Given this list of marker genes MT-ND4L, MT-ATP8, MT-CO3, MT-ND3, MT-TS2, MT-ND1, MT-TR, ELAC2, TRNT1, MT-ND6, MT-TW, MT-ND2, MT-CO2, MT-TN, MT-TL1, MT-TL2, MT-TK, MT-TC, MT-TQ, MT-TG, MT-CYB, MT-ND4, MT-ND5, TRMT10C, MT-TI, PRORP, MT-TF, MT-ATP6, MT-CO1, MT-TT, MT-TP, MT-TA, MT-TD, MT-TS1, MT-TV (mitochondrially encoded tRNA-Val (GUN)), MT-TH, HSD17B10, MT-RNR1, MT-TY, MT-TM, MT-TE, MT-RNR2, here is a description of the gene set: Each strand of the circular mitochondrial genome is transcribed to yield long polycistronic transcripts, the heavy strand transcript and the light strand transcript, which are then cleaved to yield tRNAs, rRNAs, and mRNAs. Mitochondrial RNase P, which is completely distinct from nuclear RNase P in having different protein subunits and no RNA component, cleaves at the 5' ends of tRNAs. RNase Z, an isoform of ELAC2 in mitochondria, cleaves at the 3' ends of tRNAs. (A different isoform of ELAC2 serves as RNase Z in the nucleus.) Unknown nucleases make additional cleavages near the 5' end of MT-CO3, the 5' end of CO1, the 5' end of CYB, and the 3' end of ND6. TRNT1 (CCA-adding enzyme) then post-transcriptionally polymerizes the universal acceptor sequence CCA onto the 3' ends of the cleaved tRNAs. In yeast, plants, and protozoa additional tRNAs encoded in the nucleus are imported into mitochondria from the cytosol, however human mitochondria encode a complete complement of 22 tRNAs required for translation and tRNA import has not been observed in mammals. Mutations that affect mitochondrial tRNA processing cause human diseases that are generally characterized by abnormalities in energy-requiring tissues such as brain and muscle. Reactome Pathway: tRNA processing in the mitochondrion species: Homo sapiens part of: tRNA processing